Given this list of marker genes Fgf4, Pik3c3, Fgf1, Fgf8, Fgf5, Fgf17, Fgf2, Frs2, Pik3cb, Fgf20, Irs2, Tlr9, Fgf16, Irs1, Kl, Pdpk1, Fgf23, Fgfr1, Pik3r2, Fgf6, Grb2, Fgf22, Them4, Fgf10, Fgf7, Flt3l, Klb, Shc1, Irs4, Fgf15, Igf2, Gab1, here is a description of the gene set: electronically inferred by orthology from the curated human pathway Reactome Pathway: IGF1R signaling cascade This event has been computationally inferred from an event that has been demonstrated in another species.<p>The inference is based on the homology mapping from PANTHER. Briefly, reactions for which all involved PhysicalEntities (in input, output and catalyst) have a mapped orthologue/paralogue (for complexes at least 75% of components must have a mapping) are inferred to the other species. part of: Signaling by Type 1 Insulin-like Growth Factor 1 Receptor (IGF1R) studied in species Mus musculus